The following is a description of a gene set: from publication Good KL, Avery DT, Tangye SG (PMID 19124732) Genes down-regulated in comparison of IgM-memory B cells versus Ig isotype switched memory B cells. Enhanced secondary Ab responses are a vital component of adaptive immunity, yet little is understood about the intrinsic and extrinsic regulators of naive and memory B cells that results in differences in their responses to Ag. Microarray analysis, together with surface and intracellular phenotyping, revealed that memory B cells have increased expression of members of the TNF receptor, SLAM, B7 and Bcl2 families, as well as the TLR-related molecule CD180 (RP105). Accordingly, memory B cells exhibited enhanced survival, proliferation and Ig secretion, as well as entered division more rapidly than naïve B cells in response to both T-dependent and T-independent stimuli. Furthermore, both IgM and isotype switched memory B cells, but not naïve B cells, co-stimulated CD4+ T cells in vitro through a mechanism dependent on their constitutive expression of CD80 and CD86. This study demonstrates that upregulation of genes involved in activation, co-stimulation and survival provides memory B cells with a unique ability to produce enhanced immune responses and contributes to the maintenance of the memory B cell pool. Human Gene Set: GSE13411_IGM_VS_SWITCHED_MEMORY_BCELL_DN species: Homo sapiens, and this is the list of marker genes: TAF4, RAD17, TMEM134, CSF2RB, ANKS1A, CLIC4, ARID5B, KANSL1L, BTN2A2, LAMC1 (laminin subunit gamma 1), TAS2R8, MEAK7, RAB11FIP2, CETP, NEK2, WDR11, USP9X, WWP2, COMMD3, TSC22D2, LRIF1, WAC, S100A10, SIK2, GSAP, VCPIP1, MFSD5, ERCC3, ZNF780B, CLK1, HSF2, SLC31A2, IFIH1, FCN1, F13A1, PPP2CB, HSPA4, ANXA1, LYSET, DENND3, ANKRD27, SGPL1 (sphingosine-1-phosphate lyase 1), ASAP1, HS3ST1, MKKS, CHPT1, UBE2E3, MBD2, SDR39U1, SQOR, SNW1, ELOA, MLX, VPS35L, REL, BAZ2B, PHLPP1, THAP11, ANK1, VAMP7, RAB4A, CRISPLD2, KLF2 (KLF transcription factor 2), VCAN, IRF8, CYB5A (NCBI Gene Id 1528), TGFBI, GALC, TMEM127, KDM6A, GNA14, ZNF85, TES, SCAF4, NT5E, NAXD, DDX5, ZNF276 (zinc finger protein 276), ATP6AP1, CPNE3, MAN2A2, FAF1, CD55, MRPS2, DAPP1, DNAJC9, SAPCD1, RPS15A, WDR91, PLAGL1, HLA-DRB1, RALA, NFU1, USPL1, SSB, HMGCS1, SACM1L, ZFP36L1, ECHDC3, PLPBP, MAPK14, WBP11, SLC25A37, NDUFS1, C3AR1, BCLAF1, NUP50, EIF4E2, LINC00623, DAAM1, PKD2, NDUFS4, WDR76, LEP, IGHV5-78 (NCBI Gene Id 90925), WDR47, DCAF10, MTERF1, HOPX, HMGB2, PGAP3, GOLPH3 (golgi phosphoprotein 3), KIFBP, RHOT1, VPS37C, STK10, RBM26, SCPEP1, EHHADH, NOTCH2NLA, PLK2, WEE1, SERTAD2, ZMYM4, DHRS7B, CLOCK, ACKR2 (NCBI Gene Id 95073), CAT, ZNF329, ERLIN1, DICER1, ITGA4 (integrin subunit alpha 4), FCGR2A, ANXA2P2, KIF22, VCL, SERPINA1, CHST15, SLC7A6, WSB2, CHST11, IDH1, EMP3, CRIP2, KDM4C, RFX1, SLC23A2, SERPINB1, NPRL2, RAP1GAP2, RFX5, LMO2, FNTA, AZI2 (NCBI Gene Id 64343), TDRD3, ZSCAN9, ZSCAN32, RAB6A, STAT3, CEP290 (NCBI Gene Id 9707), CNIH4, PURA, COCH, RWDD3, GFPT1, SENP6, CERNA1, ALDH2, AHR, CUL1, TSNAX, PMPCA, LGALS3, HPSE (heparanase), TNFAIP3, RTN3, DACT1, PPP2R5A, CMPK1, DNAJC13 (NCBI Gene Id 285196), UVRAG, MTMR3, CFD, SECISBP2, GUCY2D, ERBIN, TMEM106C, SCFD1